The following is a description of a gene set: studied in species Mus musculus electronically inferred by orthology from the curated human pathway Reactome Pathway: BBSome-mediated cargo-targeting to cilium part of: Cargo trafficking to the periciliary membrane This event has been computationally inferred from an event that has been demonstrated in another species.<p>The inference is based on the homology mapping from PANTHER. Briefly, reactions for which all involved PhysicalEntities (in input, output and catalyst) have a mapped orthologue/paralogue (for complexes at least 75% of components must have a mapping) are inferred to the other species., and this is the list of marker genes: Smo, Sstr3, Cct2, Cct5, Rab3ip, Bbs1 (NCBI Gene Id 52028), Bbs10, Mchr1, Cct8, Bbs7, Bbs2, Lztfl1, Ttc8, Cct3